The following is a description of a gene set: studied in species Homo sapiens Human Gene Set: GOBP_PROGESTERONE_BIOSYNTHETIC_PROCESS The chemical reactions and pathways resulting in the formation of progesterone, a steroid hormone produced in the ovary which prepares and maintains the uterus for pregnancy. Also found in plants., and this is the list of marker genes: FSHB (NCBI Gene Id 2488), DGKQ, EGR1, LHB, SCP2, ADM, STARD3